Given this list of marker genes DNAAF3, SLC26A9, HYDIN, COMT, DDRGK1, CARMIL2, SERPINA1, CCNO, MGP, NCF2, ODAD2, DNAAF5, OFD1, PTPN22, CEACAM6, DCTN4, CTLA4, NME5, KCNJ6, RPGR, UFD1, TBX1, MPEG1, CCDC40, KIF22, NFIX, SPAG1, JMJD1C, WIPF1, SLC9A3, BLM, DNAAF11, GLA, TBX20, LRRC56, SCNN1G, DNAAF4, HLA-DPA1, WAS, XPNPEP2, PRTN3, RSPH1, IDS, NCF4, SLC26A2, GATA6, NKX2-5, NCF1, HMOX1, RSPH9, DNAH9, FGFR2, GP1BB, TGFB1, DNAH1, CFAP221 (NCBI Gene Id 200373), MIF (NCBI Gene Id 4282), GCLC, DNAAF1, DNAL1, GUSB, ENG, DRC1, SPEF2, THSD4, FOXJ1, DNAH11, DNAJB13, APC, SEC24C, ODAD1, ODAD3, STK36, BTNL2, CYBB, KCNN4, CCDC39, ARVCF, MYH6, ODAD4, CFAP74, GATA4, HLA-DRB1, NEK10, RAC2, ZSWIM6, HIRA, CFAP298, GAS2L2, ZMPSTE24, EDNRA, CEACAM3, CFAP300, ALMS1, CFTR, F12 (coagulation factor XII (Hageman factor)), LMNA, RSPH4A, NME8, DNAH5, GNE, SH3BP2, DNAAF2, FGFR3, VPS33A, STX1A, DNAI1, SOX9, COL11A1, CLCA4, SCNN1A, AHDC1, CITED2, ZMYND10, POGLUT1, SLC11A1, DNAI2, ACTC1, SLC6A14, POR (NCBI Gene Id 96440), NFKB1, RREB1, GSTM3, MCIDAS, CYBC1, CYBA, DNASE1L3, SCNN1B, TLL1, HLA-DPB1, RSPH3, TTC12, HFE, DNAAF6, here is a description of the gene set: studied in species Homo sapiens Obstruction of conducting airways of the lung. Airway obstruction Human Gene Set: HP_AIRWAY_OBSTRUCTION